Given this list of marker genes DNAJC7, CAPN6, CNOT6, UBXN11, UTRN, AP4S1, SEPTIN7, PAGR1, PAX3, SOCS5, ZBTB16, ADCY6, IFT80, ABCB9, SLC6A3, EDIL3, GFI1B, TRIOBP, NEK7, ADAT1, WIPF1, POLR3D, AHCYL2, TBX21, NEDD4, P2RY4, SLC13A2, PTK7, CD27, C5orf22, SHISA5, ARF3, MTO1, CHIC2, OSR2 (NCBI Gene Id 116039), GTPBP6, RNF17, WNT8B, STAP1, ELF4, ADCY7, CXCR6, TOR4A, PPP1R8, SLCO1A2 (NCBI Gene Id 6579), GIT2, CSNK1E, HNRNPUL1, IL12RB2, AIDA, NIPA2, ZBTB8OS, GPR34, SLC22A12, DRG1, SEPTIN8, C19orf12, IGKC, DPT, HERC4, GIMAP1, IRAG1, C2orf42, YY1, PAX5 (paired box 5), TENM1, SOCS1, FXR2, LGALS9B, CD48, XIAP, C11orf16, FAS, TOP1, POLDIP3, LDB2, GRAMD1A, TMBIM6, MRFAP1L1, CAMKV, HYOU1 (NCBI Gene Id 10525), SYTL1, HINFP, FUBP1, EEIG1, TSC22D4, GPR132, ZNF623, NPAS1, CHPF, PTN, ZNF638, MDFIC, TXNDC5, ZBTB7B, KLB, HSP90B1, CASKIN2, MBOAT2, KAT6A, USP8, PROK2, OIT3, CIAO2B, CCNG1, ASPA, SIRT7, CDH16, AQP9, FRMD5, NCF4, FAM8A1, YWHAZ, CNGA1, LDB1, ARL6IP1, TSPAN13, NFE2L2, TENT5C, IRF9, TSHZ2, AZI2, CAND1, AMIGO1, MICU1, GFOD2, DUSP11, FAM174B, ITM2B, STAT1, RTL8C, GCNT3, MPRIP, SP3, ST8SIA4, TRIP12, PDE4A, HDAC1, CCND3, WNT5B, JCHAIN, IL4, N4BP2L1, IRGM, MIS12, ECM1, RBM6, TLR6, CLDN3, MORF4L1, KY, PTGER4, C1orf159, HOXB3, MTMR1, RBM10, CA1, SLC2A3, PARP14, INPP1, WDTC1, ZDHHC20, CORO2A (NCBI Gene Id 7464), USP18, PICALM, PDE4DIP, ZNF260, TEX11, SGCE, DYNC1I2, SS18 (NCBI Gene Id 6760), F2R, GRK2, CORT, TAB2, CHRNB3, ZC2HC1C, TRIM59, RARG (retinoic acid receptor gamma), RAPGEF6 (Rap guanine nucleotide exchange factor 6), RNF167, LYSMD2, NOS1, IKBKE, CHTOP, CMTM8, TAS1R1, KRT25, OGDH, RAC2, SPTB, CYTH1, HOXA4, CPB1 (carboxypeptidase B1), MAPK14, C3orf38, CENPC, LTA, PCOLCE, here is a description of the gene set: species: Homo sapiens from publication Darce J, Rudra D, Li L, Nishio J, Cipolletta D, Rudensky AY, Mathis D, Benoist C (PMID 22579475) The aim of this study was to quantify the impact of chimeric Foxp3-GFP protein on the Treg cell transcriptional program. Genes down-regulated in Foxp3-ires-GFP T reg (FOXP3+): B6 versus NOD background. Human Gene Set: GSE37605_C57BL6_VS_NOD_FOXP3_IRES_GFP_TREG_DN